Given this list of marker genes Slc25a5, Slc25a4, Slc28a1, Slc29a2, Slc29a3, here is a description of the gene set: This event has been computationally inferred from an event that has been demonstrated in another species.<p>The inference is based on the homology mapping from PANTHER. Briefly, reactions for which all involved PhysicalEntities (in input, output and catalyst) have a mapped orthologue/paralogue (for complexes at least 75% of components must have a mapping) are inferred to the other species. Reactome Pathway: Transport of nucleosides and free purine and pyrimidine bases across the plasma membrane studied in species Mus musculus electronically inferred by orthology from the curated human pathway part of: Transport of vitamins, nucleosides, and related molecules